The following is a description of a gene set: species: Mus musculus The process in which hormones modulate the force with which blood passes through the circulatory system. A hormone is one of a group of substances formed in very small amounts in one specialized organ or group of cells and carried (sometimes in the bloodstream) to another organ or group of cells, in the same organism, upon which they have a specific regulatory action. Mouse Gene Set: GOBP_REGULATION_OF_SYSTEMIC_ARTERIAL_BLOOD_PRESSURE_BY_HORMONE, and this is the list of marker genes: Ednrb, Prep, Tacr1, Agtr1b, Ece1, Ace, Rps6ka2, Rasl10b, Cyp11b2, Kcnn4, Avpr1a, Mas1, Mrgprd, Avpr1b, Avpr2, Serpinf2, Drd3, Ren1, Cyp2j5, Mme, Comt, Oxtr, Enpep (glutamyl aminopeptidase), Agtr1a, Edn3, Gja5, Anpep, Ace2, Nox1, Prcp, Ace3, Cpa3, G6pdx, Corin, Agt, Rhoa, Edn1, Klk1b26, Sucnr1, Nkx2-1, F2rl1 (F2R like trypsin receptor 1), Drd5 (NCBI Gene Id 13492), Or51e2, Mcpt4, Nos3, Nr3c2, Ndst2, Hsd11b2, F2r, Agtr2, Atp6ap2, Cyba, Edn2